The following is a description of a gene set: Human Gene Set: VANDESLUIS_NORMAL_EMBRYOS_DN from publication van de Sluis B, Muller P, Duran K, Chen A, Groot AJ, Klomp LW, Liu PP, Wijmenga C (PMID 17371845) Genes down-regulated in normal 9.5 days post coitus (dpc) embryos compared to normal 8.5 dpc and 9.5 dpc embryos. studied in species Mus musculus COMMD1 (previously known as MURR1) belongs to a novel family of proteins termed the copper metabolism gene MURR1 domain (COMMD) family. The 10 COMMD family members are well conserved between vertebrates, but the functions of most of the COMMD proteins are unknown. We recently established that COMMD1 is associated with the hepatic copper overload disorder copper toxicosis in Bedlington terriers. Recent in vitro studies indicate that COMMD1 has multiple functions, including sodium transport and NF-kappaB signaling. To elucidate the function of Commd1 in vivo, we generated homozygous Commd1 null (Commd1(-/-)) mice. Commd1(-/-) embryos died in utero between 9.5 and 10.5 days postcoitum (dpc), their development was generally retarded, and placenta vascularization was absent. Microarray analysis identified transcriptional upregulation of hypoxia-inducible factor 1 (HIF-1) target genes in 9.5-dpc Commd1(-/-) embryos compared to normal embryos, a feature that was associated with increased Hif-1alpha stability. Consistent with these observations, COMMD1 physically associates with HIF-1alpha and inhibits HIF-1alpha stability and HIF-1 transactivation in vitro. Thus, this study identifies COMMD1 as a novel regulator of HIF-1 activity and shows that Commd1 deficiency in mice leads to embryonic lethality associated with dysregulated placenta vascularization., and this is the list of marker genes: HBZ, PF4, ALAS2, IAPP, SLC39A6, NUDT4, HBG1, HBE1, PCOLCE, HOXC10, KCNH2, TESK1, CRTC1, OR1E2, HP1BP3, HS3ST1, POP4, HBA2, BASP1, CABP1, VIM